Given this list of marker genes ZIC2, GLI2, FGF8, WLS, SIX3, ALX3, DLL1, EPG5, GAS1, DDX59, NUAK2, CRIPTO (cripto, EGF-CFC family member), KDM6A, POLR1A, TGIF1, STAG2, CILK1, PLCH1, DISP1, INTU, STIL, PTCH1, HYLS1, FGFR1 (fibroblast growth factor receptor 1), NEK1, H4C3 (H4 clustered histone 3), FOXH1, SHH, NODAL, CDON, ZSWIM6, SMO, PIGN, SMC1A, KMT2D, RIPK4, GJA1, DYNC2LI1, OFD1, TCTN3, here is a description of the gene set: Median cleft upper lip A type of cleft lip presenting as a midline (median) gap in the upper lip. species: Homo sapiens Human Gene Set: HP_MEDIAN_CLEFT_UPPER_LIP